The following is a description of a gene set: Coxa vara Human Gene Set: HP_COXA_VARA species: Homo sapiens Coxa vara includes all forms of decrease of the femoral neck shaft angle (the angle between the neck and the shaft of the femur) to less than 120 degrees., and this is the list of marker genes: PCYT1A, COL9A3, DMP1, NKX3-2, COL1A2, DVL1, XYLT1, RMRP, RUNX2, TONSL, ENPP1, KDELR2, COL27A1, AIFM1, PRG4, FLNB, COL10A1, POP1, COL1A1, SLC2A10, ADAMTSL2, SLC26A2, FKBP10, IHH, TTI1, ATP7A, TRAPPC2, HSPG2, MEGF8, FZD2, MATN3, WNT5A, FN1, COMP, COL2A1, ATP6V0A2, DVL3, CRTAP, EXTL3, CSGALNACT1, TBX4, DYM, EXT1, ORC6, ADAMTS2, COL9A2, EXT2, TRPV4, NFIX, CFAP410, PEX5, DNAJC21, MMP13, RSPRY1, SERPINF1, TCIRG1, RNU4ATAC, COL9A1, PCNT (NCBI Gene Id 9346), UFSP2, RAD21, CCN6, DDRGK1, SRP54, RPL13, SBDS, SLC4A10, CANT1